Given this list of marker genes SMARCE1, NFKB2, KDM1A, POU1F1, ROBO1, LHX4, SMARCB1, MEN1, SUFU, ARMC5, FOXA2, PROP1, TERT, BAP1, AKT1, TRAF7, CDH23, PDE11A, GNAS, PRKAR1A, HESX1, NF2, SOX3, LHX3, OTX2, PIK3CA, PDGFB, AIP, GLI2, SMO, here is a description of the gene set: The concentration of corticotropin, also known as adrenocorticotropic hormone (ACTH), is below the lower limit of normal in the blood circulation. Decreased circulating ACTH concentration Human Gene Set: HP_DECREASED_CIRCULATING_ACTH_CONCENTRATION species: Homo sapiens